Given this list of marker genes PPIF, VASP, IFI6, CD59, PNPLA2, LAMB3, GKN2, BASP1, CREB3L1, CBR1, ELF3, STK24, KCNK1, PSAPL1, MGST3, SPIRE2, CA2, S100P, PGRMC2, REP15, RIOK3, ABCC5, HACD3, FAM177B, CD151, S100A14, FA2H, CTNNA1, SGSM3, YWHAH, PTTG1IP, BCAS1 (NCBI Gene Id 8537), GKN1, TFF2, OCLN, MARCKS, MIDN, CAPN5, MAL2, LGALS4, CYP2C18, MYL12B, CEACAM5, PLAAT2, PLXNB2, TCF7L2, SLC44A2, SYTL2, VSIG1, TNFRSF21, H1-0, IFI27, SPTSSB, TESC, TMEM54 (NCBI Gene Id 113452), LGALS9C, FHL2, EPN1, ALDH3A1, CAPN9, KLF3, ALDOC, CAPN8 (calpain 8), JPT1, ITPR3, IL1R2, GALE, EPS8L3, CYP2S1, MAPK3, LMNA, ACTB, JUP, PLA2G10, SLPI, CD63, GSTP1, KRT19, MT1G, CRIP1, KLF4, DNM2, ARL14, ID1, MLPH, ABHD2, TSPAN1, SLC5A5, ALDH2, C15orf48, SPINK1, ABLIM1, MAL, TST, CYSTM1, AHNAK, ANG, ARPC2, CTSE (cathepsin E), CYP3A5, IBTK, FOXQ1, PRR15, UNC5B-AS1, S100A6, ESRP1, FOXA3, IL1RN (interleukin 1 receptor antagonist), LGALS3, TFF1, FLNB, EFHD2, MX2, SLC7A8, MYH14, FCGRT, NET1, GSN, PCSK7, ACTN4, TAGLN2, RNASE1, ARHGEF2, SH3BGRL3, CLTB, RAB27A, RBM47, PSCA, SLC9A1, CD164 (CD164 molecule), MYL6, PAQR8, DSG2, RIPK4, SYNJ2, FOXA2, DHRS7, COL17A1, LINC01559, OAS1 (2'-5'-oligoadenylate synthetase 1), YWHAZ, DSC2, RNF128, HSPB1, KRT8, DYNLL1, LRP10, AKR1C3, ATP2A3, RDH13, SULT1C2, AKR1C2, HIGD1A, MGLL, ETNK1, UNC5B, ABCC3, AKR1C1, LINC01133, TENT5A, EPS8L1, FXYD3 (FXYD domain containing ion transport regulator 3), TSPAN3, GPX2, SOSTDC1, SPATS2L (spermatogenesis associated serine rich 2 like), FCGBP, MYL12A, HES1, SMIM22, MT2A, AKR1B10, MUCL3, KRT20, TSKU (NCBI Gene Id 25987), CLDN18, KLF2, IGFBP4, NAPEPLD, VILL, EHBP1L1, SECTM1 (NCBI Gene Id 6398), VAMP8, NEAT1, RASEF, PHGR1, RHOC, TACSTD2, SCNN1A, CES2, MXD1, NQO1, EEIG1, ARPC1A, DDX60, S100A11, CCND1, POLD4, TMSB4X, TSPAN8, LMO7, ANXA10 (NCBI Gene Id 51436), EFNB2, PLAC8, PRKCD, CSTA, TPM4, HPGD, ZBTB7C, PKIB, CTNNBL1, SPINT1, SMIM14, TCEAL9, SNX9, VSIG2, SPINT2, EZR, MUC1, RAC1, VEGFA, CFL1, DUOX2, TUBA1C, here is a description of the gene set: species: Homo sapiens Human Gene Set: BUSSLINGER_GASTRIC_MATURE_PIT_CELLS from publication Busslinger GA, Weusten BLA, Bogte A, Begthel H, Brosens LAA, Clevers H (PMID 33691112)